The following is a description of a gene set: Catalysis of the transfer of a diphosphate group from one compound (donor) to a another (acceptor). studied in species Mus musculus Mouse Gene Set: GOMF_DIPHOSPHOTRANSFERASE_ACTIVITY, and this is the list of marker genes: Tpk1, Prps1l3, Prps1, Prps2, Prps1l1